The following is a description of a gene set: Reactome Pathway: S Phase part of: Cell Cycle, Mitotic DNA synthesis occurs in the S phase, or the synthesis phase, of the cell cycle. The cell duplicates its hereditary material, and two copies of the chromosome are formed. As DNA replication continues, the E type cyclins shared by the G1 and S phases, are destroyed and the levels of the mitotic cyclins rise. species: Homo sapiens, and this is the list of marker genes: PSMC4, RFC2, CDC26 (NCBI Gene Id 246184), AKT2, GINS4, PSMA6, FEN1, CKS1B, PSMD2, UBE2D1, PSMD7, ANAPC7, MCM3, PSMA1, RFC5, MCM6, RPA1, PSMB3, SKP1, ORC3, E2F4, ORC2, GINS1, MCM2, RBBP4 (RB binding protein 4, chromatin remodeling factor), POLE, LIN9, ANAPC15, TFDP2, UBC, MNAT1, GINS2, STAG1, E2F1, CCNE1, PSMD14, POLA1, UBA52, PSMD12 (NCBI Gene Id 5718), PSMB6, POLE2, SMC1A, PSMD1, PSMA2, POLD4, PSMA7, CDC25A, ORC5, UBE2E1, AKT3, UBE2C, UBB, CDC25B, PSMB4, CDKN1B, MCM7, PCNA, POLA2, ANAPC2, CDT1, CDK7, PSMB2, CDCA5, PSMC1, PSMD11, MCM5, PRIM1, POLD3, MAX (MYC associated factor X), GINS3, PSMC5, PDS5B, RBL2, CABLES1, E2F5, PSMC2, CCNA2, CDC27 (NCBI Gene Id 996), ANAPC4, RFC4, RFC3, PSMB1, RPA2, ANAPC16, ORC6, PSMA4, RAD21, LIN54, CCNE2, SMC3, PDS5A, LIN52, PSMC3, RPS27A, POLD2, PSMD6, TFDP1, ANAPC1, RB1, ADRM1, UBE2S (ubiquitin conjugating enzyme E2 S), LIN37, POLE3, CDK2, POLD1, RPA3, PSMA5, GMNN, CCNA1, CDK4, MCM8, WEE1, LIG1, ORC4, SKP2, CDKN1A, WAPL, RBX1, PSMD13, ANAPC10, PSMA3, ANAPC5, CDC6, CUL1, CCND1, RFC1, ANAPC11, PSMC6, MCM4, CCNH, FZR1, PSMD8, PSMB5, PSMD3 (NCBI Gene Id 94019), ORC1 (origin recognition complex subunit 1), AKT1, ESCO2, DNA2, PRIM2, SEM1, ESCO1, POLE4, CDC23, CDC16, STAG2, CDC45, PSMB7, GSK3B, PTK6, MYC